The following is a description of a gene set: Regulation of insulin secretion Mouse Gene Set: REACTOME_REGULATION_OF_INSULIN_SECRETION studied in species Mus musculus, and this is the list of marker genes: Cacna1c, Acsl3, Gng2, Acsl4, Slc2a1, Gnb2, Slc2a2, Gng4, Itpr1, Gng10, Gng11, Glp1r, Adra2c, Gng13, Gng3, Gnb5, Marcks, Plcb3, Rapgef4, Ffar1, Cacna2d2, Gnb1 (guanine nucleotide binding protein (G protein), beta 1), Rapgef3, Plcb1, Gnaq, Cacnb2, Gng5, Gna11, Cacna1d, Cd36, Cacnb3, Kcns3, Abcc8, Cacna1e, Gna14, Gnas, Gng8, Adcy5, Kcnc2 (NCBI Gene Id 544750), Gnb4, Kcng2, Adra2a, Itpr3, Rap1a, Gcg, Gnb3, Gng7, Gna15, Prkacb, Gngt1, Gnai2 (G protein subunit alpha i2), Plcb2, Kcnj11, Cacna1a, Gng12, Kcnb1, Prkaca, Adcy6, Gnai1, Itpr2 (inositol 1,4,5-triphosphate receptor 2), Gngt2